Given this list of marker genes LIMS2, FLNC, VASP, LIMS1, RSU1, FERMT2, ILK, ACTN1, ACTB, PARVA, ITGB1, TESK1, FBLIM1, PARVB, PXN (paxillin), ACTG1, FLNA, ARHGEF6, here is a description of the gene set: Cell-extracellular matrix (ECM) interactions play a critical role in regulating a variety of cellular processes in multicellular organisms including motility, shape change, survival, proliferation and differentiation. Cell-ECM contact is mediated by transmembrane cell adhesion receptors, such as integrins, that interact with extracellular matrix proteins as well as a number of cytoplasmic adaptor proteins. Many of these adaptor proteins physically interact with the actin cytoskeleton or function in signal transduction. <br>Several protein complexes interact with the cytoplasmic tail of integrins and function in transducing bi-directional signals between the ECM and intracellular signaling pathways.<br>Early events that are triggered by interactions with ECM, such as formation/turnover of Focal Adhesions, regulation of actin dynamics and protrusion of lamellipodia to promote cellular spreading and motility are modulated by PINCH- ILK- parvin complexes (see Sepulveda et al., 2005). A number of partners of the PINCH-ILK-parvin complex components have been identified that regulate and/or mediate the functions of these complexes. Interactions with some of these partners modulate cytoskeletal remodeling and cell spreading. Reactome Pathway: Cell-extracellular matrix interactions part of: Cell junction organization studied in species Homo sapiens